The following is a description of a gene set: studied in species Mus musculus Mouse Gene Set: GOBP_POSITIVE_REGULATION_OF_FOLLICLE_STIMULATING_HORMONE_SECRETION Any process that activates or increases the frequency, rate or extent of the regulated release of follicle-stimulating hormone., and this is the list of marker genes: Smad4, Lep, Acvr2a (activin receptor IIA), Foxl2, Inhbb